Given this list of marker genes NS, PB1, PA, HA, NA, NP, M, PB2, here is a description of the gene set: studied in species Homo sapiens part of: Virus Assembly and Release The process by which influenza virus particles bud from an infected cell is not very well understood. Accumulation of M1 at the inner leaflet of the plasma membrane is thought to be the trigger for the initiation of bud formation. This bud formation continues until the inner core of the virus is completely enveloped. Completion of the budding process requires the membrane at the base of the bud to fuse. Although M1 is thought to be the driving force for bud formation, other viral and cellular proteins have been demonstrated to affect size and shape of the virus particle. Generally, influenza virus particles are either spherical or filamentous and this characteristic morphology is genetically linked to the M segment. Host factors such as polarization and the actin cytoskeleton play a critical role in determining the shape of filamentous particles. Reactome Pathway: Budding